Given this list of marker genes CTSL, CCT2, CAP1, TRAPPC1, GPC4, PADI2, SGSH, CTSA, PRSS2, LYZ, HPSE, GDI2, TXNDC5, CCT8, TOLLIP, ELANE (NCBI Gene Id 6417), HYAL1 (NCBI Gene Id 3373), CPPED1, DYNC1H1, HEXB, PRTN3, OGN, CTSB, EPDR1, PYCARD, DSN1, ARSA, GBA1, DEFA3, CSPG4, FABP5, ACAN, VAT1, NPC2, C6orf120, PSAP, PRSS57, GPC6, OMD, S100A7, HEBP2 (heme binding protein 2), GUSB, HGSNAT, PRF1, PLAC8, SMPD1, CYB5R3, ACTR2, CD74, CTSD (NCBI Gene Id 196214), TUBB4B, FUCA2 (alpha-L-fucosidase 2), PYGB, FTL, DEFA1, HEXA, NAPRT, LGMN, CSPG5, PRDX6, LAMP2, ARSB, SDC1, CTSK, CTSG, GYG1, PTGES2, NEU4, ACTR10, SDC3, APOB, RETN, RNASE2, AZU1, ARG1, MANBA, CBLIF, GLA, PRELP, FAF2, ARHGAP45, KERA, HSPA8, NSG1, GAA, IST1, GPC1, BPI, GM2A, PLBD2, MNDA, ANXA2, CHID1, CLN5, GCA, CTSC, ADA2 (NCBI Gene Id 51816), DPP7, CSF3, BGN, FASLG, DEFA1B, GALC, LIPA, GNS, BCAN, IDUA, C3, DCN, MAN2B2, NHLRC3, GPC2, DNAJC3, CTSS, RNASE3, FMOD, NAAA, TCN2, SERPINA3, GPC5, GC, UNC13D, SCARB2, CUBN, IMPDH1, IDS, ACP2, FUCA1, CTSF, HSP90AA1, MPO, AGRN, MAPK1, SERPINB3, IFI30, STK11IP, PRKCD, SDCBP, CD1E, VCP, GZMB, PA2G4 (proliferation-associated 2G4), PPT2 (NCBI Gene Id 9374), SDC4, ACLY, PDGFRB, LUM, PLD3, AGA, CTSV, GPC3, NSG2 (NCBI Gene Id 51617), NEU1, VCAN, DAPK2, NCAN (neurocan), ASAH1, TUBB, CREG1, HSPG2, RNASET2, PPT1, HRNR, GRN, MAN2B1, SDC2, FRK (fyn related Src family tyrosine kinase), ORM2, SERPINB13, PSMD1, ATP13A2, GLB1 (galactosidase beta 1), NAGLU (N-acetyl-alpha-glucosaminidase), SPACA7, TTR, GALNS, TPP1 (tripeptidyl peptidase 1), GGH, here is a description of the gene set: Human Gene Set: GOCC_VACUOLAR_LUMEN studied in species Homo sapiens The volume enclosed within the vacuolar membrane.